Given this list of marker genes BECN1, PRKCA, MIR214, MIR34B, AKAP6, MIR19A, NR4A3, EDN1, MYMK, MIR34C, TWF1, MTPN, MEF2A, MIR17, IGF1 (insulin like growth factor 1), AGT, CAMK2D, TRPC3, PPP3CA, HAND2, BMP10, MIR20A, MIR199A1, MIR208A, ROCK2, ADRA1A, PARP2, MIR21, ARRB1, ADCY10, ARRB2, ROCK1, APLNR, PDE9A, PARP1, IL6ST, SLC9A1, MIR19B1, here is a description of the gene set: Human Gene Set: GOBP_POSITIVE_REGULATION_OF_MUSCLE_HYPERTROPHY Any process that activates or increases the frequency, rate or extent of muscle hypertrophy. species: Homo sapiens